The following is a description of a gene set: Any process that results in a change in state or activity of a cell or an organism (in terms of movement, secretion, enzyme production, gene expression, etc.) as a result of a cortisol stimulus. Cortisol is the major natural glucocorticoid synthesized in the zona fasciculata of the adrenal cortex; it affects the metabolism of glucose, protein, and fats and has appreciable mineralocorticoid activity. It also regulates the immune system and affects many other functions. Human Gene Set: GOBP_RESPONSE_TO_CORTISOL species: Homo sapiens, and this is the list of marker genes: KLF9 (NCBI Gene Id 687), SLIT2, IGFBP7, SLIT3, CAD, GKN2, NR3C1